The following is a description of a gene set: BCR signaling pathway Human Gene Set: PID_BCR_5PATHWAY studied in species Homo sapiens from publication Schaefer CF, Anthony K, Krupa S, Buchoff J, Day M, Hannay T, Buetow KH (PMID 18832364), and this is the list of marker genes: CD72, BCL10, NFKB1, MAP4K1, MAPK14, NFKBIA, SHC1, PTPRC, PPP3CA, PDPK1, BCL2A1, IKBKG, CD79B, CD22, FCGR2B, POU2F2, PLCG2, MAP2K1, RAC1, CSK, NFATC1, VAV2, JUN, SYK, NFKBIB, CHUK, PIK3R1, RAF1, ELK1, MAP3K7, PPP3CC, AKT1, LYN, DAPP1, RELA, PIK3CA, MALT1, PPP3CB, IKBKB, MAPK1, GRB2 (NCBI Gene Id 80715), CAMK2G, PTEN, CD79A, CSNK2A1, MAP3K1, SOS1, SH3BP5, TRAF6, CARD11, FOS, MAPK8, RASA1, BLNK, MAPK3, PAG1, BTK, ETS1, IBTK, DOK1, CD19, PTPN6, HRAS